The following is a description of a gene set: species: Homo sapiens Human Gene Set: REACTOME_METABOLISM_OF_AMINE_DERIVED_HORMONES Metabolism of amine-derived hormones, and this is the list of marker genes: TPO, DDC (dopa decarboxylase), ASMT, TSHB, PNMT, AANAT, DBH, TH, DIO3, SLC5A5, IYD, DUOX1, DIO2, DUOX2, CGA, TPH2, TPH1, DIO1